Given this list of marker genes GSTO1, IL22 (NCBI Gene Id 57328), TWIST1, UBE2N, NOD2, IL5, GSTA2, SKP1, HSP90AA1 (heat shock protein 90 alpha family class A member 1), HSP90B1, IL1A, PTPN14, MEF2C, IL17F, IFNL1, IL10RA (interleukin 10 receptor subunit alpha), HNRNPDL, JUN (NCBI Gene Id 3725), IL27RA, IL37, RPS6KA3, N, RAG1, CCL19, IL13 (NCBI Gene Id 96500), IL22RA2, IFNL2, PRKACA, IRS1, CISH, PTPN5, PELI2, LIF, IL9, TAB2, ITGB1, PSMB2, IL18, IL5RA, NOS2, MAPK10, IL12RB1 (interleukin 12 receptor subunit beta 1), PTPN12, PTK2B, IRAK2, MAP3K8, PTPN13, CHUK, IL17A, 8, CSF1, CTF1, IL4R, HGF, IFNG, NANOG, LCN2, VIM (vimentin), TNIP2, FOXO3, PSMD2, PSMD13 (proteasome 26S subunit, non-ATPase 13), SDC1, CUL1, PTPN18, LCP1 (NCBI Gene Id 3936), FOS, CCL4, H3C1, ITGAX, PPP2R1B, MEF2A, SMARCA4, VEGFA, PPP2CB, HSPA9, PSMA4, PSMB6, VAMP2, BOLA2, PSMD1, RPS6KA1, PRTN3, H3C15, TSLP, S100A12, IL11, IL25, STAT1, IL31, PTAFR, CSF2, VRK3, OPRM1, IL31RA, PIK3CD, TRAF6, COL1A2, FPR1, CNTF, PSMD11, INPP5D, P4HB, IKBIP, RHOU, TALDO1, OSMR (oncostatin M receptor), MAPK8, ADRM1, PTPN20 (protein tyrosine phosphatase non-receptor type 20), IRF4, PPP2R1A, SIGIRR, OSM, RELA, IGHG1 (NCBI Gene Id 3500), TBK1, S1PR1, CANX, LCK, CASP3, PSMC4, MMP2, MAP3K3, CBL, HSPA8, PSMB4, SNAP25, VAMP7, CTSG, PSME2, MMP9, SEM1, CRLF1, MIF, PSMB3, FOXO1, ARF1, IL1RAPL1, IL9R, ALPK1, SOCS5, CXCL1, STAT5B, GAB2, CXCL2, IKBKB, IL36RN, LAMA5, IL12A, CASP1 (caspase 1), MAPK7, MAOA, PIK3R3, PITPNA, CAPZA1, FASLG, N4BP1, CD80, MAP2K7, SOCS2, CDKN1A, IL18R1, CFL1, IRAK3, CXCL8, MYD88, PSMC1, STXBP2, SYK, IL13RA2, FN1, IL17RB, PTPN6, MCL1, TP53, MAP2K1, OPRD1, IL13RA1, STX4, TIFA, YWHAZ, ZEB1, SOS1, IL10, TNF, IL15, BCL6, ANXA1, RAP1B, MUC1, LBP, RAG2, PDCD4, STAT4, PSMA7, LRRC14, HNRNPF, IL15RA, IL17RA (interleukin 17 receptor A), ALOX15, SERPINB2, UBE2V1, AGER, IL24, MAP3K7, SOD2, RPS6KA5, IL36G, CCL11, NLRX1, DUSP3, PPP2CA, NFKB1, CRK, IL7R, UBB, CCL5, IFNLR1, CDC42, CRLF2, IL17RE, IRS2, RPS27A, SMAD3 (NCBI Gene Id 51521), CXCL10, PSMB5, PIK3R1, IGHG4 (immunoglobulin heavy constant gamma 4 (G4m marker)), GRB2, MAP2K4, IL1R1, TRAF2, SAA1, MAPK14, STX3, YES1, BIRC5, USP14, MMP3, POU2F1, IL12B, IL17C, FYN, MYC, DUSP7, IL34, IL3RA, CCL3L1, PSMC5, POMC, PPIA, PSMA5, MSN, PTPN7, HAVCR2, PAK2, PIK3CB, PTPN2, S100B, IRAK4, MAPK1, IL20RB, PTGS2, RBX1, IL36B, MTAP, BRWD1, IGHE, JAK1, CCL3, IL1RL2, TXLNA, IL2RG, RPLP0, DUSP6, CREB1, PSMC2, IL1RL1, HMGB1, PSMD7, TGFB1, STAT3, SHC1, IL2 (NCBI Gene Id 3558), PSMB1, CCL22 (NCBI Gene Id 6367), ITGB2, SOD1, PSMA2, IL20, HNRNPA2B1, F13A1, PTPN23 (NCBI Gene Id 96248), PTPRZ1, IL17RC, RORC, MAP2K6, MAPK3, FSCN1, AKT1, IL7, BTRC (NCBI Gene Id 8945), PTPN4 (protein tyrosine phosphatase non-receptor type 4), BLNK, TOLLIP, TNFRSF1B, CCR5, NDN, CA1, STAT2, PPP2R5D, LGALS9, IL1RAP, PSMA1, CSF2RB, PELI1, IL27, BATF, TIMP1, IL16, ATF1, APP, IL21, TNFRSF1A, ANXA2, IFNL3, RALA, CASP8, CEBPD, IL2RA, CRKL, IL20RA (interleukin 20 receptor subunit alpha), SOCS1, SOX2, CNN2 (calponin 2, NCBI Gene Id 1265), MAPK11, IL1R2, SNRPA1, IRAK1, RORA, CCND1, SOS2, CCR1, IL21R, PSMB7, IL26, BCL2, IL18RAP, CSF3R, EBI3, PELI3, FCER2, IL1F10, IL32, IL10RB, SQSTM1, IL1B, RPS6KA2, NKIRAS1, CSF2RA, JAK2, CLCF1, FBXW11, STAT5A, FGF2, VAV1, PIK3R2, ICAM1, MAPKAPK2, GATA3, PSMD14, PTPN11, MAPK9 (mitogen-activated protein kinase 9), PSMD3, PTPN9, GSDMD, MAP2K3, PIM1, UBA52, TEC, HMOX1, IL11RA, IL23R, CSF1R, IL6R, IL4, CD86, NFKBIB, CSF3, IL19, NFKBIA, PSMA6, STX1A (syntaxin 1A), ITGAM, IL23A, ELK1, CD4, PSMD6, IKBKG, SOCS3, ATF2, STAT6, CD36, NFKB2, LIFR, LMNB1, NKIRAS2, CCL2 (NCBI Gene Id 6347), PSMC3, IL18BP, CCL20, USP18, PSMD12, BCL2L1, PSMA3, AIP, UBC, TAB3, RAPGEF1, IL1RN, IL6ST, IL22RA1, IL33, IL3, MMP1, MAPKAPK3, JUNB (NCBI Gene Id 90482), TCP1, PIK3CA, NOD1, VCAM1, PSMC6, HIF1A, RIPK2, LYN, JAK3, TYK2, IL12RB2, CNTFR, INPPL1, NLRC5, IL6, IL2RB, IL36A, TAB1, ALOX5, HCK (NCBI Gene Id 3055), PSMD8, CCR2, DUSP4, here is a description of the gene set: species: Homo sapiens Reactome Pathway: Signaling by Interleukins Interleukins are low molecular weight proteins that bind to cell surface receptors and act in an autocrine and/or paracrine fashion. They were first identified as factors produced by leukocytes but are now known to be produced by many other cells throughout the body. They have pleiotropic effects on cells which bind them, impacting processes such as tissue growth and repair, hematopoietic homeostasis, and multiple levels of the host defense against pathogens where they are an essential part of the immune system. part of: Cytokine Signaling in Immune system